Given this list of marker genes ACADM, HADH, ECHS1, HADHA, HADHB, MECR, here is a description of the gene set: Reactome Pathway: Beta oxidation of decanoyl-CoA to octanoyl-CoA-CoA studied in species Homo sapiens part of: mitochondrial fatty acid beta-oxidation of saturated fatty acids The fourth pass through the beta-oxidation spiral picks up where the last left off with the saturated fatty acid decanoyl-CoA and produces octanoyl-CoA. Four enzymatic steps are required starting with MCAD CoA dehydrogenase (Medium Chain) activity, followed by the enoyl-CoA hydratase activity of crotonase, the 3-hydroxyacyl-CoA dehydrogenase activity of the short chain 3-hydroxyacyl-CoA dehydrogenase (SCHAD), and completed by the ketoacyl-CoA thiolase activity, present in the mitochondrial membrane associated trifunctional protein. Note that the 3-hydroxyacyl-CoA dehydrogenase activity of SCHAD is not actually limited to short chain fatty acids, in fact SCHAD has a broad substrate specificity.